Given this list of marker genes DKK1, SOX2, POU5F1, CDX2, EOMES, GSC (NCBI Gene Id 2927), NANOG, HHEX, GATA6, TSC22D1, here is a description of the gene set: POU5F1 (OCT4), SOX2, NANOG repress genes related to differentiation species: Homo sapiens Human Gene Set: REACTOME_POU5F1_OCT4_SOX2_NANOG_REPRESS_GENES_RELATED_TO_DIFFERENTIATION